The following is a description of a gene set: Human Gene Set: GOBP_NEGATIVE_REGULATION_OF_VASCULAR_ASSOCIATED_SMOOTH_MUSCLE_CELL_APOPTOTIC_PROCESS studied in species Homo sapiens Any process that stops, prevents or reduces the frequency, rate or extent of vascular associated smooth muscle cell apoptotic process., and this is the list of marker genes: MIR21 (microRNA 21), IGF1, SLC7A5, MIR17, MIR138-1, DNMT1, MIR210